The following is a description of a gene set: electronically inferred by orthology from the curated human pathway Reactome Pathway: APC:Cdc20 mediated degradation of cell cycle proteins prior to satisfation of the cell cycle checkpoint studied in species Mus musculus part of: APC/C:Cdc20 mediated degradation of mitotic proteins This event has been computationally inferred from an event that has been demonstrated in another species.<p>The inference is based on the homology mapping from PANTHER. Briefly, reactions for which all involved PhysicalEntities (in input, output and catalyst) have a mapped orthologue/paralogue (for complexes at least 75% of components must have a mapping) are inferred to the other species., and this is the list of marker genes: Psma4, Psmc2, Psmd7, Cdk1, Ube2d1, Psma6, Anapc2, Psmc5, Anapc7, Mad2l1, Psmc4, Psmc3, Psma1, Psmb7, Psmc1, Psma2, Psma3, Psma7, Psmd6, Ubb, Ube2e1, Ube2c, Anapc10, Ccna1, Psmb6, Psmb4, Psmc6 (NCBI Gene Id 67089), Anapc15, Cdc23, Rps27a, Psmd13, Psma5 (NCBI Gene Id 26442), Psmd12, Ube2s, Psmd1, Cdc26, Psmb5